Given this list of marker genes gag, PPIA, vpr, vpu, gag-pol, vif, rev, here is a description of the gene set: species: Homo sapiens Reactome Pathway: Plus-strand DNA synthesis part of: Reverse Transcription of HIV RNA Two specific polypurine tracts (PPT sequences) in the viral RNA, one within the pol gene (central or cPPT) and one immediately preceding the U3 sequence (3' PPT), are spared from degradation during minus strand DNA synthesis and prime plus-strand synthesis. At least two discrete steps of DNA replication, removal of the PPT RNAs and the tRNA primer that initiated minus-strand synthesis, and a strand transfer lead to the synthesis of a linear duplex DNA corresponding to the full length of the HIV genomic RNA with long terminal repeat (LTR) sequences at both ends. Both DNA synthesis and RNA degradation are catalyzed by domains of the HIV-1 reverse transcriptase (RT) heterodimer. During plus-strand synthesis, Preston and colleagues observed secondary sites of plus-strand initiation at low frequency both in the cell-free system and in cultured virus-infected cells.